Given this list of marker genes Ndufa13, Flna, Map2k2, Aip, 2210016L21Rik, Abt1, Jtb, Ndufb9, Fam89b, Tbrg1, Mrps21, Cdkn2d, Hpf1, Mcemp1, H2aj, Chrac1, Cfl1, Batf, Card19, Mrpl12, Dlgap4, Sri, Rala, Brk1, Ptma, Pin1, Pglyrp1, Med8, Mrps11, Psmd10, Spsb2, Ly6c2, Ndufa6, Ndufb10, Hcfc1r1, Lamtor3, Npc2, Mrpl46, Eef1d, Erh, Atp5mc2, Trappc6a, Calm1, Fau, Txn1, Rbm8a, Ilkap, Ctss, Mrpl33 (NCBI Gene Id 66845), Rpl14, Nosip, Mrpl18, Tomm6, Gar1, Smim8, Ppp1r11, Psmb8, Sdhc, Drap1, Uqcrq, Ifitm2, B2m, Eif3g, Polr2j, Gnptg, Mien1, Lyz2, Clta, Snrpb, Smim30, Enoph1, Ino80b, Micos13, Gstp1, Exosc6, Tmem223 (NCBI Gene Id 66836), Nfkbib, Lage3, Tbcb, Ndufaf8, 2310061I04Rik, Cuta, Ino80e, Pbdc1, Arpc3, Mpc2, Sugt1, Asf1a, Mrpl30 (NCBI Gene Id 69516), Abcg1, Pttg1, Gng10, Mfsd10, H1f2, Rpp21 (NCBI Gene Id 67676), Dnajc19, Bbln, Retnlg, Ptprcap, Cope, Mphosph8, S100a13, Gabarapl2 (NCBI Gene Id 93739), Jund, Crlf2, Ppdpf, Nabp2, Stmp1, Mrpl14, Manbal, Bcl7c, Elob, Dad1, Eif3k, Sumo1, Ube2l6, Rtraf, Rps20, Lamtor4, Mydgf, Psmb9 (proteasome (prosome, macropain) subunit, beta type 9 (large multifunctional peptidase 2)), Mospd3, Prdx5, Polr1h, Bnip3l, Rhog, Med29, Mpv17l2, Supt4a, Grcc10, Ube2k, Use1, Tecr, Oaz1, Plaat3, Arhgdib, BC005624, Klf13, Lamtor1, Gabarap, Ubb-ps, 2810004N23Rik, Svbp, Lypla2, Ddrgk1, Nedd8, Mrpl27, Atp5mf, Susd3, Surf1, Scand1, Sf3b2, Prdx6, Wbp2, Psmg1, Psmb4, Atp6v0e, Ttc7, Spi1, Tmsb10, Park7, Cox6b1, Ndufs6, Ftl1, Rps27, Tmem147, Elof1, Sf3b4 (NCBI Gene Id 223612), Pfdn1, Myl6, Rpl17, Cdk2ap2, Serf2, Gpx4, Grina, Mcrip1, Thyn1, Trappc1, Mrpl57, Selenos, Rpl24, Rabac1, Bloc1s1, Tmem50a, Wbp4, Arpc5l, Atp5f1c, H3c1, Rps9, Trmt112, Zmat5, Fth1, Abi3, Cd9, Dctpp1, Limd2, Idnk, Ssbp4, Med10, Mettl26, Tnfaip8l2, Ndufc2, Wbp1, Selenok, Trir, Aup1, Ndufs7, Rbm39, Mrps15 (mitochondrial ribosomal protein S15), 2410006H16Rik, Gemin7, Gmfg, Igbp1, Mrps17, Ntpcr (nucleoside-triphosphatase, cancer-related), Cd81, Apoe, Gps2, Rab8a, Slpi (NCBI Gene Id 20568), Psma7, Psmd4, Psmc4, Clpp, Selenow (NCBI Gene Id 20364), Psmb2, Bcl2a1b, Mlf2, Sdhb, Uqcrb, Ssu72, Krtcap2, Kdelr1 (NCBI Gene Id 68137), Srp14, Ubxn4, Pfn1, Znhit1, Dtnbp1, Arrb2, Fxyd5, Pfdn2, Stx8, Glipr1, Akt1s1, Med28, Npm3, Pts, Malat1, Luc7l3, Timm22, Shisa5, Snrpd3, Aurkaip1, Nme3, Zdhhc4, Slu7, Thap7, Fcer1g, Ccdc32, Fyb1 (FYN binding protein 1), Rplp2, Lrg1, Mrpl17, Camp, A930005H10Rik, Rnaset2b, Pqbp1, Emp3, Rilpl2, Dmac1, Frg1, Rnaseh2a, Mrpl51, Pagr1a, Atp5mc3 (ATP synthase membrane subunit c locus 3), Ap4s1, U2af1, Fcgr4, Rps18, Pam16, Atp6v0b, Rnaseh2c, Tmem134, Cox14, Rexo1, Mrto4, Atp5pd, Srgn, H2-Eb1, Rnasek, Trappc2l, Ifitm3, Arpc4, Chmp2a, Mmp8, Rex1bd, S100a8, Vti1b, Cyba, Lsm4, Tmem11, Tmem60, Mpc1, Utp3, Emc10, Mvb12a, Eif3f, Snx20, Dpm1, Ndufa5, Aprt, Rab5if, Mrpl54, Cd74, Ndufs4, Ndufb8, Prelid1, Ubl5, Pfdn6, Ppp1r18, Tmem128, Vamp8, Faim, Flt3l, Exosc3, Polr2e, Fis1, H3f3b (NCBI Gene Id 78941), Antkmt, S1pr4, Polr2i, Tex261, Wdr83os, Sys1, Ppp1r35, Sf3b5, Ccdc85b, Ubxn1, Tuba4a, Rpl6, U2af1l4, Rps3, Grpel1, Fkbp3, Prr13, Gpx1, Snrpc, Jchain, Ifi35, Tm2d3, Tma7, Sft2d1, Cstb, Mrpl41, Zcchc17, Ostc, Adrm1, Edf1, Rps10, Atp6v1f, 2310039H08Rik, Rpl22, Atp6v1g1, Commd7, Pebp1, Anp32a, Tmsb4x, Anapc11, Pgls, Emd, Bag1, 1110038F14Rik, Pstk, Mrps23, Bri3, Tusc2, Ndufb7, Rps7, Mrpl34, Vps28, Rpl13, Ttc1, Nme6, Psme2, Chchd7, Qng1, Rexo2, Rbfa, Rpl18, Atp5if1, Psmb6, Hsd17b8, Skic8, Gng5, Tspo, Tmem234, Srsf9, Utp11, Saysd1, Dnlz, Tmem208, Rpl13a, Gsn, Cib1, Gadd45gip1, Rpl22l1, Sec11c, Ckb (NCBI Gene Id 12709), Lsm2 (LSM2 homolog, U6 small nuclear RNA and mRNA degradation associated), Mrpl19, Iah1, Srsf5, Bbc3, Atp5f1d, Cst3, Trappc6b, Cirbp, Plekhj1, Lcn2, Cfdp1, Cotl1, Mrps26, Sra1, Cd37 (NCBI Gene Id 12493), Acot13, Ipo13, Brca2, Emc7, Nol7, A430005L14Rik, Atp5mc1, Ndufa10, Bax, Cox7a2l (cytochrome c oxidase subunit 7A2 like), Tmem14c, Timm13, Zcrb1, Dnajc15, Bscl2, Rpl35, Dguok, Psmb10, Pdrg1, Brd4, 2310011J03Rik, Tmed9, Ypel3, Myl12b, S100a6, Ccdc12, Sdf4, 1810009A15Rik, Calm3, Tmed10, Atp5mg, Pih1d1, Mrps12, Rp9, H2-Ab1, Zc3h8, Wdr18, Vcf1, Wfdc17, Rfxank, Abhd17a, Mrps24, Sin3b, Rab2a, Arpc1b, Tmem160, Mrps34, Nop53, Rpl19, Mrpl36, S100a11, Swi5, Gpsm3, Apbb1ip, Cycs, Mad2l1bp, Snrpa1, Dctn3, Cox5a, Faap20, Nme2, Tle5, Guk1, Ybx1, Tsn, Dynlrb1, Gnb2, Lamtor2, Pomp, Lsp1, Ccdc124, Syf2, Cd63, Uqcr10, Ndufb11, Pold4, Csnk2b, Etfb, Cenpx, Atp5po, Vasp, Rpl10a, Ndufa8, Hacd2, Exosc5, Pfdn5, Ndufa11, Ltb, 2510002D24Rik, Bsg, Lgals3, Reep5 (receptor accessory protein 5), Mea1, Lime1, Mrpl58, Snapc5, Szrd1, Ap2s1, Mmp9, Rps13, Eri2, Ube2m, Ubb, Dnpep, BC031181, here is a description of the gene set: Mouse Gene Set: TABULA_MURIS_SENIS_MARROW_NK_CELL_AGEING species: Mus musculus from publication Tabula Muris Consortium (PMID 32669714)